The following is a description of a gene set: The cohesin complex loads onto chromatin in telophase, but its association with chromatin remains transient, dynamic until the S-phase of the cell cycle, presumably because the cohesin-bound NIPBL:MAU2 (SCC2:SCC4) complex promotes chromatin loading, while cohesin-bound WAPAL promotes dissociation from chromatin. Stable binding of cohesin complexes to chromatin, measured by a mean residence time on chromatin, is triggered by DNA replication in S-phase, consistent with establishment of sister chromatid cohesion. <br><br> In S-phase, acetyltransferases ESCO1 and ESCO2 acetylate the SMC3 cohesin subunit. The acetylation of SMC3, in addition to DNA replication and the presence of PDS5 on cohesin, facilitates the recruitment of CDCA5 (Sororin) to cohesin complexes, an essential step in the establishment of sister chromatid cohesion in mammalian cells. CDCA5 (Sororin) displaces WAPAL from PDS5, thus preventing WAPAL to interfere with the establishment of sister chromatid cohesion. The establishment and temporal regulation of sister chromatid cohesion is necessary for equal segregation of replicated chromosomes to daughter cells. Reactome Pathway: Establishment of Sister Chromatid Cohesion species: Homo sapiens part of: S Phase, and this is the list of marker genes: STAG2, CDCA5, RAD21, ESCO1, SMC3, PDS5A, PDS5B, STAG1, SMC1A, WAPL (WAPL cohesin release factor), ESCO2